Given this list of marker genes DMC1, SCN7A, TMEM63A, ERCC6, RAD51B, GCN1, MSH5, RAD51, MAP3K20, SLC38A9, TMEM63C, PELO, GMPPA, UHRF1, MICU2, SYT7, SYT11, EFHB, PMS2, NOX4, PMS2P1, SYT3 (synaptotagmin 3), NDUFS2 (NCBI Gene Id 4720), SYT10, ARFIP2, HIF1AN, ZNF598, TMEM63B (transmembrane protein 63B), GCKR, MSH4, EFHD1, PICK1, RAD51C, SYT4, NLRP3, SYT13, SYT6, SAR1A, TRPV4, SIRT6, PARK7, MSH3, MSH2, SYT1, EGLN2, SYT8, CASTOR1, PMS2P3, SYT9, EFCAB9, SYT15, MSH6, XPC, PMS1, SLC39A4, XRCC2, ICA1, SAR1B, MICU3 (NCBI Gene Id 286097), MLH3 (NCBI Gene Id 27030, mutL homolog 3), PMS2P6, RAD23B, GCK, SYT17, PMS2P5, TRPA1, SYT5, PKD2L1, SYT12, MICU1, XRCC3, SYT2, RAD51D, MLH1, here is a description of the gene set: Human Gene Set: GOMF_MOLECULAR_SENSOR_ACTIVITY Binding to a molecule and eliciting a change in the protein's activity in response to the intracellular level of that molecule. species: Homo sapiens